Given this list of marker genes FLT3, here is a description of the gene set: Gilteritinib is a second-generation type I tyrosine kinase inhibitor with activity against FLT3. This pathway describes FLT3 mutants that are resistant to inhibition by gilteritinib. Reactome Pathway: gilteritinib-resistant FLT3 mutants species: Homo sapiens part of: Drug resistance of FLT3 mutants